The following is a description of a gene set: Mouse Gene Set: GOBP_POSITIVE_REGULATION_OF_ACROSOME_REACTION studied in species Mus musculus Any process that activates or increases the frequency, rate or extent of the acrosome reaction., and this is the list of marker genes: Fam170b, Plb1, Prss37, Pla2g10, Glra1, Zp3, Cacna1h, Iqcf1, Plcb1, Ccdc87